The following is a description of a gene set: Absent palmar crease Human Gene Set: HP_ABSENT_PALMAR_CREASE species: Homo sapiens The absence of the major creases of the palm (distal transverse crease, proximal transverse crease, or thenar crease)., and this is the list of marker genes: SLC39A13, SLC18A3, DOK7, KIF21A, MYH3, RAPSN, MYOD1, NALCN, NUP88, TUBA1A, PIEZO2, RIPK4, MUSK, MAGEL2